The following is a description of a gene set: Mouse Gene Set: GOBP_PEPTIDYL_LYSINE_DEACETYLATION The removal of an acetyl group from an acetylated lysine residue in a peptide or protein. species: Mus musculus, and this is the list of marker genes: Sirt2, Hdac9, Sirt4 (sirtuin 4), Hdac4, Hdac6, Sirt3